The following is a description of a gene set: Mouse Gene Set: GOBP_POSITIVE_REGULATION_OF_NUCLEOTIDE_BINDING_DOMAIN_LEUCINE_RICH_REPEAT_CONTAINING_RECEPTOR_SIGNALING_PATHWAY Any process that activates or increases the frequency, rate, or extent of a nucleotide-binding domain, leucine rich repeat containing receptor signaling pathway (NLR) pathway. species: Mus musculus, and this is the list of marker genes: Hspa1b, Slc15a3, Slc46a2, Slc15a4, Nagk, Peli3, Tlr4